Given this list of marker genes Lypd1, Chrng, Trpc1, Gnai2, Rgs8, Tspo, Slurp2, Grxcr1, Chrna4, Large1, Ly6h, Chrm1, Rgs10, Sorbs1, Chrnb1, Lynx1, Stim1, Plcb1, Prkcb (protein kinase C, beta), Chrnb2, Itpr1, Ly6g6e (NCBI Gene Id 70274), Ly6g6g, Anxa7, Orai1, Chrna6, Sorbs2, Ly6a, Hrh3, Chrna7, Ly6g, Chrna1, Psca, Chrne, Ly6c2, Hrh4, Chrna3, Ache, Chrm4, Bloc1s6, Chrna5, Ly6g2, Ly6g6d (NCBI Gene Id 319640), Chrnb3, Chrna2, Ly6f, Chrnd, Cdk5r1, Rock2, Chrnb4, Ly6e, Ly6c1, Chrm2, Ly6m, Atp2b4, Ly6i, Crkl, Ednra, Chrm5, Gnaq, Oprm1, Gna11, Chrm3, here is a description of the gene set: Any process that results in a change in state or activity of a cell or an organism (in terms of movement, secretion, enzyme production, gene expression, etc.) as a result of an acetylcholine stimulus. Mouse Gene Set: GOBP_RESPONSE_TO_ACETYLCHOLINE studied in species Mus musculus